Given this list of marker genes MCCC1, AGXT2 (NCBI Gene Id 64902), GPT2, BCKDK, HMGCLL1, AGXT, GPT, IVD, MCCC2, AUH, HMGCL, here is a description of the gene set: Human Gene Set: GOBP_PYRUVATE_FAMILY_AMINO_ACID_CATABOLIC_PROCESS studied in species Homo sapiens The chemical reactions and pathways resulting in the breakdown of any amino acid that requires pyruvate for its synthesis, e.g. alanine.